Given this list of marker genes Exoc4, Exoc7, Exoc2, Exoc1, Exoc8 (exocyst complex component 8, NCBI Gene Id 97490), Exoc3, Exoc6, Exoc5, Exoc6b, here is a description of the gene set: The initial, indirect interaction between a secretory vesicle membrane and a site of exocytosis in the plasma membrane. This interaction is mediated by tethering factors (or complexes), which interact with both membranes. Interaction can occur via direct binding to membrane phospholipids or membrane proteins, or via binding to vesicle coat proteins. This process is distinct from and prior to docking and fusion. species: Mus musculus Mouse Gene Set: GOBP_VESICLE_TETHERING_INVOLVED_IN_EXOCYTOSIS